Given this list of marker genes CBR4, EHHADH, MLXIPL, TECRL, OXSM, INSIG2 (insulin induced gene 2), FADS2B, ELOVL1, ALOX12B, PTGS2, FASN, PRKAB2, PNPLA8, EIF6, ABHD3, APOA5, ACOX1, SLC45A3, ELOVL6, ACSS2, PNLIPRP3, NR1H2, ABHD1, CYP1A1, MIR185 (NCBI Gene Id 406961), HSD17B8, MIR30C1, KLHL25, GPIHBP1, CBR1, MIR766, APOA4, MGLL, CYP2C8, MIR342, ACSM5, PTGS1, NDUFAB1, CYP2E1, FADS1, CTHRC1, ACSL4, ALOX5, LTC4S, AKR1C3, ACSM4, ACSF3, PLAA, CD74, ANGPTL4, IL1B, MID1IP1, PRKAB1 (protein kinase AMP-activated non-catalytic subunit beta 1), GSTM4, HACD2, EDN2, FADS6, ACSM6, ACSL1, PLP1, SCP2, QKI, MIR182, FA2H, ACADL, TBXAS1, EDN1, MCAT, ACSS1, MECR, PIBF1, APOC1, PTGDS, PNLIP, ERLIN2, TRIB3, OLAH, ABCD3, PRKAA1, ACSM2B, PDK4, HSD17B12, ACSBG2, MIR33A, PRKAA2, TMEM135, BRCA1, HTD2 (NCBI Gene Id 109729165), CYP7A1, PRKAG3, DECR2, ACADVL, PTGIS, SCD5, AVPR1A, ELOVL7, PRKAG2, ALOX15, PLA2G4F, PLA2G1B, ELOVL2, HACD4, ABCD1, CYP3A4, CEACAM1, ACACA, ELOVL4, LPGAT1, ASAH2, TECR, ELOVL3, ACSBG1, HPGDS, SCAP, FADS3, ACACB, ACOT4, GSTP1, SIRT2, GIP, MIR548P, MIR132, UBR4, FADS2, DEGS1, PNLIPRP1, ACSM1, DCAF5, DAGLB, PTGES2, PECR, HACD3, ELOVL5, ACSM3, HACD1, ABHD2, MIF, ERLIN1, AVP, KAT2B, PTGES3, CYP2D6, INSIG1, ACOT7, ACOT8, WDTC1, ALOX15B, PTGES (NCBI Gene Id 9536), PLA2G4A, APOC3, MIR96, ABCD2, SCD, SIRT1, APOC2, MLYCD, ALOXE3, PNLIPRP2, PRXL2B, HSD17B4, LIPC, GSTM1, XBP1, PLA2G10, NR1H3, ACSM2A, THNSL2, CYP1A2, PLA2G3, ACLY, GSTM2 (NCBI Gene Id 82152), LPL, CYP2C9, MIR204, LIPG, PRKAG1, FABP5, LIAS, ALOX12, GPX4, here is a description of the gene set: The chemical reactions and pathways resulting in the formation of a fatty acid, any of the aliphatic monocarboxylic acids that can be liberated by hydrolysis from naturally occurring fats and oils. Fatty acids are predominantly straight-chain acids of 4 to 24 carbon atoms, which may be saturated or unsaturated; branched fatty acids and hydroxy fatty acids also occur, and very long chain acids of over 30 carbons are found in waxes. Human Gene Set: GOBP_FATTY_ACID_BIOSYNTHETIC_PROCESS species: Homo sapiens